The following is a description of a gene set: species: Homo sapiens Human Gene Set: GOBP_REGULATION_OF_AMIDE_METABOLIC_PROCESS Any process that modulates the frequency, rate or extent of the chemical reactions and pathways involving amides., and this is the list of marker genes: BIN1, RPTOR, ORMDL2, MIR29C, ROCK1, IFNG, PIN1, NFE2L2, MIR29A, EFNA1, PDK2, MIR24-1, PRKAA1, ZNF750, MIR103A1, MIR206, SPHK2, MIR29B1, CCN1, EPHA4, MIR15A, MTOR, SORL1, SIRT3, CHRNA7, ORMDL1, CLU (NCBI Gene Id 1191), ABCG1, SLC2A13, MIR339, SP1, RTN2, CSNK1E, GSK3A, ROCK2, MIR195, PRKCD, SLC7A11, PDK3, ABCA7, TNF, TNFRSF1A, MIR127, IGF1, MIR16-1, TIGAR, PGK1, DYRK1A, SPON1, TP53, NTRK2, MLST8, LRRTM3, MIR455, TPK1, BCKDK (branched chain keto acid dehydrogenase kinase), SNCA, RTN1, ORMDL3, GGA3, MIR15B, SCARB2, SPHK1, GSAP, ALDOB, PAQR4, IFNGR1, PDK1, PLA2G6, HAP1, NSMAF, PICALM, MIR186, ABCA2, MIR361, MIR153-1, MIR298, APOE, RELA, SAMD8 (NCBI Gene Id 142891), PDK4, PRNP, RTN4, RTN3 (reticulon 3), CASP3, TMED10, ENPP7, NR1H4